Given this list of marker genes CLYBL, TGIF1, PIGY, MOCS2-DT, HYLS1, RPS27L, GDPD1, ZNF500, IDH2, LIN7B, NPRL3, EMB, UVSSA, GSK3B, RABGAP1, SLC35A1, YPEL2 (NCBI Gene Id 388403), CLOCK, HEXA, KAT7, NELFB, HSD17B11, CHD9, GTF2IRD2, AP1G2, ZNF398, MPP1, MARCHF8, CAPS, METTL23, ADI1, CPNE1, UCP2 (uncoupling protein 2), ZKSCAN4, DCAF17, SLC35E2A, RPS6KA1, SLC37A4, TM7SF2, VDAC3, CHST14, EXOC4, RAD52, PIGZ, H2AC25, CMC1, MAP3K12, HECA, LINC03104, NR1D2, RBM45, ZNF449, ANKRA2, CRACR2A (NCBI Gene Id 84766), KIAA0319L, FHIP2A, ASAH1 (N-acylsphingosine amidohydrolase 1), PNISR, AGK, KNL1, ZNF518A, PCCB, PPARA, C2CD5, CMPK1, CAMK4, TPK1, YIPF1, SLC7A6OS, TMEM94, ATP6V1G1, ACAT2, KIAA0586, ANAPC5, ILK, ZBP1, ZNF224, SAC3D1, FBXW4, BBS1, PRORP, VPS36, FBXO9, ZNF776, ZFAND1, TMEM179B, HSDL2, SMAD2, MAP2K5, ZNF276, UBR7, TRIM46, SPG11, PPP1R12B, GPD1L, CDK5RAP2, SLC24A1, IGIP, TMEM101, DPEP2, CIAO2A, PNRC1, DHFR2, KDM5A, KDM3B (NCBI Gene Id 51780), TMEM204, SDHAF4, ASL, FGD3, FOXJ2, LINC02035, CBFA2T2, MRPL43, ATMIN, ARB2A (NCBI Gene Id 83989), SIGIRR, MPND, MARCHF9, TBC1D14, ARSK, ITIH4, TRERF1, HEATR5B, DENND10, AKR1B1, ZNF33A, UBA7, SLC25A20, PCBD2, KDELR1, KIAA1143, SDCBP2, ANXA11, TBCK, RABGGTA, GPALPP1, ACAT1, LRRC37A2, GUSBP11, KIAA2013, NIN, ERCC6L2-AS1, SDHA, ATP7B, GYS1, OPN3, AGAP3, MON2, EIF2AK1 (eukaryotic translation initiation factor 2 alpha kinase 1), VIPAS39, SPIN4, SURF1, SLA2, ZNF138, INPP5D, KIF22, SPEN-AS1, RNPEPL1, DNASE1L1, TAFAZZIN, ZNF766, CNPY3, OSBPL7, CDKN2D, IDH1, ARIH2OS, SKA2, SAP30L, H2BC21, ASPRV1, ACAP1, PURA, TMEM129, ARHGAP15, STMN3, B3GNT2, HINFP, TRMT1L, PKN2, LIX1L, DENND6A, MAP2K6, RETREG2, COMMD9, VILL, ANXA4, EXOC1, RFX7 (regulatory factor X7), TCF19, LIN9, TMEM19, DHFR, ARHGEF6, ACBD6, IRAK4, SH3BGRL, here is a description of the gene set: Innate lymphoid cells (ILCs) are a recently recognized heterogenous group of immune cells that are critical in orchestrating immunity and inflammation in the intestine, but whether ILCs influence immune responses or tissue homeostasis at other mucosal sites remains poorly characterized. Here we identify a population of lung-resident ILCs in mice and humans that expressed the alloantigen Thy-1 (CD90), interleukin 2 (IL-2) receptor a-chain (CD25), IL-7 receptor a-chain (CD127) and the IL-33 receptor subunit T1-ST2. Notably, mouse ILCs accumulated in the lung after infection with influenza virus, and depletion of ILCs resulted in loss of airway epithelial integrity, diminished lung function and impaired airway remodeling. These defects were restored by administration of the lung ILC product amphiregulin. Collectively, our results demonstrate a critical role for lung ILCs in restoring airway epithelial integrity and tissue homeostasis after infection with influenza virus. As part of this study, we performed gene expression profiling to examine how the transcriptional signatures compared between murine naïve group 2 lung ILC and group 3 splenic LTi cell populations. Genes up-regulated in lung innate lymphoid cells versus spleen CD4 T cells. species: Homo sapiens from publication Monticelli LA, Sonnenberg GF, Abt MC, Alenghat T, Ziegler CG, Doering TA, Angelosanto JM, Laidlaw BJ, Yang CY, Sathaliyawala T, Kubota M, Turner D, Diamond JM, Goldrath AW, Farber DL, Collman RG, Wherry EJ, Artis D (PMID 21946417) Human Gene Set: GSE46468_LUNG_INNATE_LYMPHOID_CELL_VS_SPLEEN_CD4_TCELL_UP